The following is a description of a gene set: Human Gene Set: TTTGCAG_MIR518A2 Genes having at least one occurence of the motif TTTGCAG in their 3' untranslated region. The motif represents putative target (that is, seed match) of human mature miRNA hsa-miR-518a-2* (v7.1 miRBase). studied in species Homo sapiens, and this is the list of marker genes: MAPRE1, DSCAML1, SATB2, RAB6C, STK38, PPP1R12A, MEIS1, RANBP10, TSHZ3, CEPT1, ANK2, WDR26, ARK2N, MIER3, RAB22A, PRKAB2 (NCBI Gene Id 5565), NDRG1, SENP7, TARDBP, CD47, CPEB2, EIF3J, DHX15, KDM5B, SORBS1, JAG1, MMD, HSPA9, TIMP2, GDF11, RNF11, PFN2, PHF6, SRSF10, PPM1F, KPNA3, R3HDM1, NEXMIF, PACSIN1, NHS, PAX3, SLC25A26, SAMD4A, AMACR, NUAK2, ACVR2A, NEDD8, ATP11A, CAMTA1, PBRM1, ANKRD17, XIAP, PLEKHM1, CNN1, MEIS2 (Meis homeobox 2), TAPT1, LEMD3, YOD1, DUSP6, ADRA2B, DOCK10, PMEPA1, QKI, MEMO1, MKRN1, LAMC1, DDX42, NRF1, FBXL5, RAP2C, SSC4D, INHBB, HNRNPR, MLEC, SPART, OSGIN2, SLC39A9, DYRK1A, GUCY2C, FAM78B, CGGBP1, ETF1, BCL2, PTGFRN, MSL2, EPB41L1, STAG2, LEF1, CDC42EP3, NCOR1, BCL11A, FOXJ3, AGFG1, KMT2C, MED13L, IVNS1ABP, PCGF5, DAPK1, NAA30, AGO2, SET, CTDP1, GADD45A, NEDD4L, CPEB4, ZIC1, DCAF5, ITCH, CEP57L1, HMGB1, FOXA1, PJA2, BRI3, FAM133B, CTNNB1, MAP3K3, MAN1A1, PURB, MYOG, PABPN1, LAMP2, FAM117A, AEBP2, GNB4, NCKIPSD, CORO1C, MCU, SF1 (NCBI Gene Id 7536), CHD9, OSBPL8, ATRN, ABTB3, HECTD1, HAPSTR1, PICALM, GID4, MIR600HG, ARRDC3, ARPP19, YTHDF3, CARF, POU4F1, KCMF1, LARP4, PCARE, SLTM, KIF3B, SEPTIN6, ZMAT1, ACTR3, LRRN3 (leucine rich repeat neuronal 3), EIF4G3, EGR3 (NCBI Gene Id 1960), RBM33, PNN, PLPPR4, CUL2, RBM25, RAI2, KCNJ2, SP8 (NCBI Gene Id 378050), CATSPER2, CDK2AP1, DKK2, PLEKHB2, RASGRP4, CHSY1, TOMM70, PLEKHA3, RAB6A, IGF2BP1, RBBP7, CBFA2T2, AFF2, SETD7, RAB21, NOVA1, TSPAN14, CREB3L2, EPB41L4B, ZFP36L1, NR3C2, RHOT1, PLCB1, ZFAND5, SIPA1L2, SGCZ, LINC02915, IP6K1, SEH1L, ANKRD28, TAF4, MMGT1, HERC2P9, AMER2, TACC1, SRPK2, CCL13, HMGA1, DSC3, HDAC4, CNNM2, UBAP2, TCF12, USP6, HMGA2, KPNA4, AGPAT5, PTPRF, CA10, SURF4